The following is a description of a gene set: The directed movement of some substance from a cell, into the extracellular region. This may occur via transport across the plasma membrane or via exocytosis. studied in species Mus musculus Mouse Gene Set: GOBP_EXPORT_FROM_CELL, and this is the list of marker genes: Lif, Ceacam1, Myo6, Rab40c, Snf8, Hmga2, Smad4, Kcnk18, Nos1, Otof, Or51e2, Cltrn, Ins2, Ralbp1, Cacna1g, Tmed10, Gnptab, Dnajc1 (NCBI Gene Id 98831), Ildr1, Zbed6, Sec24a, Nsf, Cyp51, Prkcq, Lmf1, Mlxipl, Mttp, Clasp1, Ucn2, Dtnbp1, Chga, Rab1a, Gpr151, Rab40b, Brsk1, Vdr, Scamp1, Sv2c, Sirt1, Rab2b, Kcnk2, Ccn3, Avpr1a, Chrna4, Snord35a, Cd38, Cpb2, Tpcn2, Kcne2, Drd3, Ccr1, Tacr2 (NCBI Gene Id 21337), Pfkl, Best1, Mtnr1b, Fxyd4, Slc9b2, Cadps2, Rhbdf1, Trpv1, Wnt7a, Srcin1, Cbl, Cacna1b, Pianp, Mup4, Il6, Exoc6, Tgm2 (NCBI Gene Id 21817), Lrp1 (NCBI Gene Id 16971), Gnai1, Rab3a, Kif5b (NCBI Gene Id 16573), Txlna, F2, Fgr, Cd160, Kit, C1qtnf1, Ptger3, Galr1 (NCBI Gene Id 14427), Syt13, Atp1b3, Trpm5, Bmp2, Pcsk1, Capn10, S100a10, Rcn3, Atp2b3, Pex5l, Fxyd5 (FXYD domain-containing ion transport regulator 5), Mmp13, Slc44a4 (NCBI Gene Id 70129), Tmed2, Nkd2, Stx11, Abcc5, C1qtnf5, Hmgcr, Cckbr, Tyro3, Hcfc1, Ghrh, Mical1, Glp1r, Anxa1, Kcnip1, Slc8a2, Pik3c2a, Abcb11, Itgb2l, Foxo1, Slc4a4, Epcip, Rimbp2, Gnaq (guanine nucleotide binding protein, alpha q polypeptide), Sv2b, Myh10, Vamp3, Myt1, Nr1h3, Myrip, Unc13d, Sacm1l, Ntrk2, Raf1, Il13ra2, Vps4b (vacuolar protein sorting 4B), Rest, Rac2, Atp1b1 (ATPase, Na+/K+ transporting, beta 1 polypeptide), Brsk2, Ppt1 (NCBI Gene Id 97141), Bglap, D6Wsu163e, Myh9, Apbb1, Gnai2 (G protein subunit alpha i2), Prkca, Stx3, Stx4a, Atp13a2, Grik5, Ttn, Oxct1, Malrd1, Smcr8, Plcd1, Lypd10, Golph3l, Sv2a, Sytl4, Mir200a, Lyst, Hcrt, Calm2 (NCBI Gene Id 75700), Fgg, Arfgap3, Ykt6, Sphk1 (NCBI Gene Id 66122), Npy2r, Pim3, Foxl2, Lypd11, Hmgn3, Washc1, Tfap2b, Igfbp3, Cbarp, Pafah1b1, Mpc2, Slc30a1, Ghrhr, Cd2ap, Ap1b1, Gnaz, Rab27a, Nppa, Nr0b2, Cntf, Vps18, Rptor, Ptgds, Nmu, Trpv6, Cftr, Xlr4b, Hamp2, Kcne3, Tunar, Sfrp1, Tmem79, Ucp2, Tbc1d1, Gpr158, Nlgn2, P2ry12, Mia3, Oga, Hap1, Nkx3-1, Syngr1, Exoc1, Gja5 (NCBI Gene Id 70659), Abcc8, Sri, Mertk, Slc22a18, Igf1, Anxa3, Ccl8, Abat, Myo5b, Efna5, Eny2, Exoc3l4, Sytl3, Rab15, Agtr1a, Exoc7, Pard6a (par-6 family cell polarity regulator alpha), Ywhae, Tph1, Rab3c, Mup11, Git2, Smpd3 (NCBI Gene Id 80691), Niban2, Serpine2, Rabgef1, Itsn1, Madd, Atp4a, Ggcx, Ang, Snord34, Il11, Osbp, Fcer1a, Hamp, Rab11fip1, Sytl2, Gzmb, Pdzd11, Cd84, Erc2, Mir130a, Adcyap1, Syt8, Prkce, Cplane2, Entpd1, Cela2a, Kcne4, Mrgprx2, Ano1, Snap25, Prkcb, Slc2a2, Cry1, Bsg, Inha, Gipc1, Tardbp, Avp, Anxa5, Htr2c, Kiss1, Vegfc, Tgfb3, Fto, Pdx1, Copg2, Dvl1, Slc38a3, Fxyd6, Syn2, Sco1, Hmga1, Abcg1, Rab37, Myo19, Uqcc2, Syt3, Nkx6-1, Vps13a, Rasgrp1, Furin, Rsad2, Il1rapl1, Ucn, Atp1b2, Exoc8, Scn11a, Chrna3, Anxa7, Il12b, Lgi3, Drd4, Tnfrsf1a, Bloc1s6, Sirt6, Snapin, Clcf1, Kcnc3, Arf1, Tmem163, Scamp5, Selenot, Rhbdd3, Tmem63b, Atg7, Abcc2, Slc6a9, Npy (neuropeptide Y), Stx1b (syntaxin 1B), Dio2, Myo5a, Ccr2, Snap29, Slc8a3, Myo1g, Gpr68, Kmo, Grin2b, Itpr1, Kcna2, Mif, Nrxn2, Pdcd6ip (NCBI Gene Id 97504), Hps6, Crhr1, Cadps, F2rl2, Ptger4, Pick1, Ppp1r9a, Kctd9, Slc16a2, Tac4, Axl, Myo18a, Ptbp1, Clnk, Ncoa6, Edn2, Llgl2, Rbm4, Trem2, Stim1, Pax8, Kpna4 (karyopherin subunit alpha 4), Grp, Tspoap1, Rtn4, Ffar4, Rab3b, Pde1c, Grxcr1, Erc1, Pnkd, Kcnb1, Lrrc8a, Rap1a, Per2, Sdf4, Chmp2a, Prkd1, Gnat1, Nr1h2, Sphk2, Myom1, Zp3, Slc30a10, Sncaip, Stxbp2, Il4, Sdc1, Rab11fip3, Crh, C9orf72, Chd7, Sytl5, Prkar1a, Tiam1, Tm7sf3, Ucn3, Doc2g, Pou5f1, Fcgr4, Pla2g3, Mrgprb1, Rab25, Tlr2, Fga, M6pr, Gata2, Sybu, Apoe, Kcnj6, Krt20, Sirt4, Efr3a, Mafa, Fmr1 (fragile X messenger ribonucleoprotein 1), Adcy5, Snca, Mon1a, Rab8a, Mical3, Htr7, Prss12, Ghsr, Rab10, Exoc3l, Unc13a, Il1a (interleukin 1 alpha), Adora2b, Ly6e, Gabbr1, Septin1, Pparg, Atp1a2, Prkg1, Map2k6, Rac1, Nkg7, Nppc, Trim9, Sar1b, Prkcg (NCBI Gene Id 18752), Apln (NCBI Gene Id 77874), Cplx2, Porcn, Ap1m2, Clstn3, Rab9 (RAB9, member RAS oncogene family), Myb, Irs2, Apbb3, Dgat1, Casr, Pomc, Rab13 (NCBI Gene Id 77496), Rgs9, Git1, Stxbp1, Chrm3, Kcnq2, Mup3, Ifnb1, Hmox1 (heme oxygenase 1), Bmp6, Dynll1, Idh2, Prf1, Tcf7l2, Akap5, Mup1, Cdk5r2, Trim72, Kcnq1, Pip5k1c, Syt10, P2ry4, Hgs, Rph3a, Syngr3, Slc47a2, Oxt, Arf6, Fgf7, Acvr2b, Slc22a2, Slc25a22, Lin7b, Nr4a3, Rab3gap1, Il12a, Ap1s1, Cavin1 (NCBI Gene Id 69669), Rims4, Mef2c, Fxyd1, Xlr4a (NCBI Gene Id 630479), Gna11, Cask, Syt1, Cry2, Lep, P2rx2, Syngr2, Crhr2, Atp4b (ATPase, H+/K+ exchanging, beta polypeptide), Trpm2, Kcnh2, Rab33b, Syt2, Aqp1, Pfkfb2, Surf4, Ric1, Kcnk1, Syk, Prkn, Gnao1, Slc47a1, Lat, Pi4k2a, Vgf, Fgfr4, C2cd2l, Grm2, Prickle1, Rab8b, Stxbp3, Ppard, Fkbp1b, Braf, Ncam1, Abr, Ptpn23, Fgfr1, Psap, Ccn2, Ncs1, Spp1, Tspan18, Ghrl, Rab11fip5, Rims1, Filip1l, Agrn, Comt, Adora1, Ica1, Nf1, Copg1, Snap23, Rfx3, Clock, Mctp2, Snx4, Micu3, Steap2, Aacs, Tmem258, Adra2a, Retn, Ffar2, Cpt1a, Bdnf, Abcg2, Gpld1, Agtr2, Atp1a1, Mia2, Septin5, Pram1, Pask, Ppid, Adora3, Htr1a, Fam3d, P3h1, Tmem167, Tmem132a, Mir410, Glud1, Exoc5, Gpr15lg, P2ry2, Pikfyve, Kcnh1, Nr1d1, Slc4a8, Fxyd2, Sycn, Septin4, Ensa, Cpe, Eipr1, Scrn1, Wls, Il1rn, Creb3l1, Stam, Atp2b1, Rfx6, Uts2, Osbpl2, Tsg101, Ankrd1, Rala, Epb41l1, Fxyd7, Tmem38b, Prepl, Slc27a1, Tfr2, Svbp, Ngf, Ang5, Il13, Plek, Napb, Lepr, Rims2, Rab5a, Slc18a2, Wnk4, Tvp23b, Pde8b, Vamp9, Slc18a1, Nnat, Adam17, Tmed10-ps, Htr1d, Syt7, Nrxn3, Nos2, Kcnd3, Wipf3, Fgf10, Bglap2, Lyn, Vps41, Tspan9, Cplx3, Ccdc186, Trpc1, Cxcl12, Pde3b, Chrnb2, Neo1, Slc6a4, Tgfb2, Serp1, Mup2, Npy1r, Cyb5r4, Edn1, Trpm4, Syt15, Rap1b, Inhba, Sel1l (sel-1 suppressor of lin-12-like (C. elegans)), Pink1, Fgb, Nmb, Gpr119, Rhbdf2, Gata3 (NCBI Gene Id 14462), Abcb1b, Arfgef2, B3glct, Trpv4, Syt12, Tspo, Orai1, Cbln1, Acvr1c, Ptgs1, Rab26, Nagpa, Tnfrsf11a, Myo1f, Rufy4, Ecrg4, Ptprn, Kcnj11, Unc13c, Rab11fip2 (NCBI Gene Id 74998), Napa, Hrh3, Slc8a1, Apba1, Piwil4, Snord33, Ccl3, Hadh, Cops5, Snap47 (synaptosomal-associated protein, 47), Slc38a5, Lat2, Casp1, C1qtnf3, Cplx1, Osm, Trpa1, Lamp1, C1qtnf12 (C1q and tumor necrosis factor related 12), Edn3, Fbxo45, Nrxn1, Cyp27b1, Vamp2, Fbxl20, Npy5r, Sucnr1, Asic1, Tmf1, Ms4a2, Cbln4, Cdk16, Selenom, Arl8b, Fcgr3, Maob, Exoc6b, Tnfaip2, Stx17, Stx2, Agt, Abca12, Ndufaf2, Grk2, Adipoq, Rab12, Arhgef7, Ptpn11, Bad, Ffar1, Vip, Syde1, Slc29a4, Tango2, Mapk9, Cck, Dnm1l, Exoc3l2, Pde4c, Kcnt2, Fcer1g, Foxa2, Mcu, Gata1, Sdc4, Dph3, Slc36a2, Nckap1l, Ap1g1 (NCBI Gene Id 52301), Sox4, Hps1, Alox5, Ang6, Synj1, Exoc2, Atp5pf, Kdm5b, Slc9a1, Cacna1e, Syn3, Fam3a, Plcb1, Slc18a3, Cyp2j5, Slc30a8, Olfm2, Slc17a3, Golph3, Creb1, Adora2a, Eqtn, Sstr5, Tac1, Prrt2, Coro1a, Ppfia2, Lrrk2, Slc16a1, Atp9a, Eng, Abcc4, Cckar, Vamp1, Epha5, Slc30a4, Rab11b, Ccl5, Atp12a, Cacna1a, Bcl2l1, Grm8, Mtnr1a, Pkd1, Abca1, Oscp1, Sdcbp, Stxbp5, Spi1, Erp29, Ptges, Pld2, Btk, Scg5, Slc24a4 (NCBI Gene Id 353057), Dlg1, Mfn2, Sergef, Syt17, Ppfia3, Syt4, Hcar2, A1cf, Syt11, Sirt3, Nr4a1, Sytl1, Scrib, Tnfrsf1b, Pcsk6, Exph5, Nisch, Lin7a, Abca3, Drd2, Tprg1l, Ltbp4, Kcnj8, Hck, Cacnb4, Ppp3cb, P2rx1, Camk2n1, Kcnc4 (NCBI Gene Id 99738), Mecp2, Syp, Ctbp2, Nlrp5, Adam9, Tnfsf11, Cdk5, Trappc11, Slc1a5, Crhbp, Trarg1, Anxa2, Rims3, Negr1, Fgf23, Mctp1, Notch1, Pcp4, Baiap3, Ptgdr, Nucb2, Vsnl1, Blk, Heph, Arfip1, Il4ra, Chrna7, Foxd1, Dab2, Llgl1, Ptpmt1, Adtrp, Tbx3, Tvp23a, Npff, Jak2, Rhot1, Snap91, Gja1, Pdpk1, Slc12a2, Gdf9, Gck, Washc5, Cga, Vamp8, Cnr1, Htr2a, Ffar3, Lrp5, Pla2g10, Gsdmd, Ppia, Rbp4, P2rx7, Kcnn4, Slc35g1, Arrb1, Fes, Htr6, Xbp1, Syt9, Bcr, Prkaca (NCBI Gene Id 18747), Birc5, Nell2 (NEL-like 2), Ube2q1, Rab11a, Cacna1c, Tcirg1, Vps11, Dgki, Mup5, Lgals3, Ptgs2, Cacna1h, Oxtr, Nr1h4, Tlr4, Gnas, Cd200, Aimp1, Gipr, Gal, Map4k4, Zfp469, Acsl4, Gcg, Sct (NCBI Gene Id 20287), Tango6, Zfp384, Cartpt, Slc8b1, F2r, Rab27b, Ano6, Rab31, Adam8, Stxbp5l, Hnf4a, Sncg, Kcnk9, Park7, Bmal1, Steap3, Klf7, Ptafr, Glul, Kiss1r (NCBI Gene Id 114229), Oprm1, Cd177, Hnf1b, Sdhd, Fbn1, Fam3b, Exoc3, Rab7, Stx1a, Neurod1, Pla2g6, Jagn1, Isl1, Gab2 (growth factor receptor bound protein 2-associated protein 2), Hif1a, Cacna1d, Gper1, Pck2, Slc40a1, Nr3c1, Idua, Cspg5, Frmd4a, Htr1b, Pak1, Ralb, Pfn2, Kcna5, Foxf1, Kcnq3, Washc3, Ahi1, Dpysl2, Mc4r, Rasl10b (RAS-like, family 10, member B), Adcy8, Camk2a, Pla2g4a, Syt5, Slc38a2, Ifng, Rapgef4, Snx19, P2ry1, Ntsr1, Tacr1, Hyal3, Sptbn2, Oprk1, Itgam, Kcnip2, Acvr2a, Ighe, Fxyd3, Nlgn1, Psmd9, Ildr2, Gpr27, Atp2a2, Egfr, G6pc2, Vps35, Htt, Sox11, Runx1, Pclo, Lin7c, Lgals9, Tcp11, Il1b, Ywhaz, Npvf, Vps4a, Nadk, Cd300a, Cacna1i, Rgcc, Rab34, Ang4, Rap1gds1, Tgfb1, Kalrn, Kcne5 (NCBI Gene Id 66240), Abcc1, Cklf, Doc2b (double C2, beta), Arhgap17, Midn, Slc30a2, Unc13b, Cyp19a1, Ednrb, Milr1, Clasp2, F2rl1, Comp, Grm7, Rab21, Ppp3ca, Ptprn2, Tspan4, Rab3d, Ptprv, Atp1a4, Snord32a, Gip, Inhbb, Stxbp4, Hnf1a (HNF1 homeobox A), Syn1, Bloc1s3, Syt6, Trh, Exoc4, Psen1, Gpr39, Tnf, Ren1, Smad2, Irs1, Slc16a10, Ier3ip1, Abcb1a, Ang2, Pfkm, Nrg1, Stx19, Doc2a, Rph3al, Tmem167b, Chrna6, Srebf1, Fzd4, Atp1a3 (ATPase, Na+/K+ transporting, alpha 3 polypeptide), Gcgr, Ep300, Gprc6a, Rab44 (NCBI Gene Id 442827), Sidt2, Ccr1l1, Ins1, Kcne1, Hfe, Itgb2, Wdr41, Cplx4